The following is a description of a gene set: The chemical reactions and pathways involving glycerophospholipids, any derivative of glycerophosphate that contains at least one O-acyl, O-alkyl, or O-alkenyl group attached to the glycerol residue. Mouse Gene Set: GOBP_GLYCEROPHOSPHOLIPID_METABOLIC_PROCESS species: Mus musculus, and this is the list of marker genes: Fig4, Atm, Serinc2, Gpam, Crls1, Ajuba, Inpp5j, Pip5k1a, Smg1, Apoa2, Plek, Plaat5, Agpat4, Pla2g6, Dgke, Pla2g4d, Gnpat, Bpnt1, Pip5k1b, Pik3r1, Plcb4, Mboat1, Oc90, Nr1h2, Inpp5d, Pigv, Abhd4, Plcl2, Pnpla3, Ip6k3, Plaat3, Pigm, Gpat2, Ldlr, Slc30a5, Inpp5k, Abhd6, Pla2g4e, Cdipt, Dbi, Inpp1, Pik3c2b, Cln3, Pnliprp2, Abhd16b, Apoc1, Lclat1, Impa2, Prdx6b, Lipc, Spata18, Lpin1, Becn1, Tnfaip8l3, Pi4k2b, Pigp, Mtmr11, Plb1, Pla2g5, Atg14, Lrat (lecithin-retinol acyltransferase (phosphatidylcholine-retinol-O-acyltransferase)), Sacm1l, Ptdss2, Pla2g4f, Htr2c, Nr1h4, Inpp5b, Itpkb, Lpcat1, Etnk1 (NCBI Gene Id 97308), Scarb1, Pigk, Pik3c3, Gpat4, Pigw, Inppl1, Ttc7b, Itpka, Agpat1, Pgap4, Mtmr6 (myotubularin related protein 6), Pigf, Plcd4, Lpgat1, Pten, Plch2, Sh3yl1, Gdpd1, Enpp2, Pi4k2a, Pla2g2e, Gpaa1, Selenoi, Dgki, Pikfyve, Inpp5e, Pla2g4b, Gpld1, Sh3glb1, Pla2g1b, Pip5kl1, Pla2g7, Pcyt1b (NCBI Gene Id 236899), Slc27a1, Pla2g10, Dhrs7b, Bpnt2, Hycc1, Ocrl, Cwh43, Chkb, Plcb1, Inpp4b, Pigb, Mtmr1, Abca3, Hadha, Pgap1 (post-GPI attachment to proteins 1), Ip6k1, Pik3r5, Htr2b, Pip4p2, Pemt, Chpt1, Pitpnc1, Pigs, Dpm3, Plcg1, Lpcat2, Dgkh, Cds1, Pyurf, Lpcat3, Pigx (NCBI Gene Id 72084), Alox15, Plch1 (phospholipase C, eta 1), Pla2g2a, Mecp2, Hycc2, Gpat3, Fgf7, Dgkk, Tamm41, Pdgfrb, Pik3cb, Apoa4, Mtmr7, Fabp5, Htr2a, Dgkg, Pdgfb, Pcyt2, Vac14, Pld1, Prdx6, Pnpla8, Mfsd2a, Hdhd5, Pign, Pla2g4c, Abhd5, Tmem150a, Pik3cd, Pgap3, Dnajc19, Pgap2, Mtm1, Ptdss1, Ptpmt1, Pon1, Pigq, Pip4k2c, Abhd16a, Uvrag, Them5, Serac1, Gpcpd1, Dgkq, Pgp, Phb2 (NCBI Gene Id 12034), Pla2g2d, Dpm1 (dolichyl-phosphate mannosyltransferase subunit 1, catalytic), Serinc5, Pdgfa, Plcg2, Pigu, Mtmr2, Naaa, Plcd1, Pigh, Smpd4, Dgka, Pigyl, Acsl3, Galr2, Inpp5a, Ttc7, Lcat, Pik3cg, Dpm2, Abhd3, Ipmk, Synj2, Mtmr10 (myotubularin related protein 10), Pigz, Pigc, Etnk2, Fabp3, Pik3c2a, Plcl1, Agpat3, Pip4p1, Nr1h3, Dgkz, Plscr1, Chrm5, Pip4k2b, Plaat1, Plce1, Pi4kb, Mtmr12, Impa1, Pgs1, Pi4ka, Abhd12, Serinc1, Mtmr4, Synj1, Chka, Pigg, Lpcat4, Pik3ca, Mboat7, Pnpla6, Pla2g2c, Agpat2, Efr3b, Pcyt1a, Gdpd3, Abhd8, Ddhd1, Napepld, Plcb2, Mtmr9, Itpkc (inositol 1,4,5-trisphosphate 3-kinase C), Pigo, Bscl2, Ptprq, Cept1 (choline/ethanolaminephosphotransferase 1), Dgkb, Tafazzin, Plscr3, Rab38, Pld2, Capn2, Piga, Pip4k2a, Ip6k2 (NCBI Gene Id 76500), Abhd12b, Inpp5f, Far1, Pisd, Mppe1, Pigl, Acp6, Pik3r4, Inpp4a, Pla2g4a, Apoa1, Pla2g3, Agap2, Mtmr3, Dgkd, Pla2g2f, Pnpla7, Pla2g15, Cds2, Pigt, Agpat5, Mboat2, Pik3c2g, Pip5k1c, Plcb3